Given this list of marker genes Anxa2, Tmsb4x, Prxl2a, Rpl35rt (NCBI Gene Id 100038991), Gm10076, Tmsb10, Gm10736, Gm11478, Igkc, here is a description of the gene set: Representative genes of 3 sub-clusters of epithelial cells species: Mus musculus from publication Zhang L, Long W, Xu W, Chen X, Zhao X, Wu B (PMID 35669188) Mouse Gene Set: ZHANG_UTERUS_C0_MATURATIONAL_UP